Given this list of marker genes Masp2, Masp1 (MBL associated serine protease 1), Fcna, Fcnb (NCBI Gene Id 14134), here is a description of the gene set: electronically inferred by orthology from the curated human pathway This event has been computationally inferred from an event that has been demonstrated in another species.<p>The inference is based on the homology mapping from PANTHER. Briefly, reactions for which all involved PhysicalEntities (in input, output and catalyst) have a mapped orthologue/paralogue (for complexes at least 75% of components must have a mapping) are inferred to the other species. Reactome Pathway: Ficolins bind to repetitive carbohydrate structures on the target cell surface species: Mus musculus part of: Lectin pathway of complement activation